The following is a description of a gene set: studied in species Mus musculus from publication Yevshin I, Sharipov R, Kolmykov S, Kondrakhin Y, Kolpakov F (PMID 30445619) Genes containing one or more binding sites for (Thap11) in their promoter regions (TSS -1000,+100 bp) as identified by GTRD version 20.06 ChIP-seq harmonization. Mouse Gene Set: THAP11_TARGET_GENES, and this is the list of marker genes: Ncln, Qrich1, Wdr45, Zfp13, Vamp1, Wdfy2, Sv2c, Kdm1a, Ccnc, Zfp398, Snord43, Vrk3, Fam53c, Zbtb8b, Acsf3, Fxr1, Zfp142, Mir1938 (NCBI Gene Id 100316693), Polr3c, Rab8b, Gtpbp2, 2310074N15Rik, Mrm3, Map3k10, Tdrd12, Zfp369, Cdc40 (NCBI Gene Id 71713), Mrpl34, Rpp30, Ksr1, Ddx49, Pex3, Polr1h, Rps27l, Bms1, Alkbh3, Zfp87, Btf3l4, Park7, Gab1, Hdac2, Adam22, Pigc, Lrrc51, Iscu, Trub1, Hcfc1r1, Cebpz, Mir6516, Marchf5, Psme3ip1, Mtmr6, Mrps10, Zscan2, 1700112D23Rik, Shpk, Klhdc3, Ints12 (integrator complex subunit 12), Slc9a1, Pigq, Rpl3, Fam222a, A530083I20Rik, Mib2, Ctdp1, Mrpl17, Slc9a8 (solute carrier family 9 (sodium/hydrogen exchanger), member 8), Glod4, Grk4, Aimp1, Zhx1, Arsk, Ubxn4 (UBX domain protein 4), Ppp1r7, Tmco1, mt-Nd6, Thoc1, Ccdc126, Sugp1, D030040B21Rik, Supv3l1, Gpt2, Suco, Snx27, Tomm20, Utp11, Cilk1, Srd5a1, Wtap, Tcf25, Fam8a1, Kif2c, Rps6kb2, 9930004E17Rik (NCBI Gene Id 654819), Cnpy3 (NCBI Gene Id 73685), Caprin2, 1700022N22Rik, Gm13610, Stx4a, Ddx18, Pemt, Gm15787, Chmp2a, H4c8 (H4 clustered histone 8), Fbxw11, Frg2f1, Pcm1, Stag3, Ighmbp2, 2500002B13Rik, Fdx2, Exo1, Zcwpw1, Cep57l1, Gstcd, Thap11 (THAP domain containing 11), Ndufb8, Slc4a2 (solute carrier family 4 (anion exchanger), member 2), Htra2, Aplf, Gpc2, Eif5b, Trmt10a, Nop14, Nfkbil1, Rnf44, Cdkn2aipnl, Cct6a, Zfp451, Psenen, Nob1, Klhl20, Xxylt1 (NCBI Gene Id 268880), Snhg16, Gid4, Napb, Ahsa1, Selenoi, Tial1, Capn15, Trappc13, Gtf2h4, Rab26os, 2610035D17Rik, Ndufaf4, Alkbh4, Gt(ROSA)26Sor, Rpl7, Kpna3, Timm22, Polr1a, 4632404H12Rik, Ube2d1, Nutf2, Trappc2b, Chmp7, Mrpl1, Foxj3, Wdfy1 (WD repeat and FYVE domain containing 1), Mir8098, Ndor1, Nosip, Gtf3c5, Vdac3, Wasf1, Pask, Klhdc4, Ube2j2, Ttc13, Smarcd1, Csrnp2, Cntd1, Calr3, Srp19, Snapc5, Mettl25b, Xpot, Lmtk3, Ift52, Cog2, Jmjd4, Agfg1, Chac2, Cox11, Otud4, Ndc1, Ablim2, Snrpd3, Ppp1r12b, Fam78a, H3f3b, Eif3c, Romo1, Zfp354c, Zcchc8, Zap70, Apba3, Calcrl, Snord14a, Iqcc, Zfp110, Srsf1, Snx3, Gm14127, Gfus, Tmem245, Haus6, Clasp1, Mtr, Ppp1r13l, Rrs1, Shmt2, Btrc, Eml6, Tbx6, Mzf1, Znfx1, Tmco3, Pfkfb2, Tssc4, Rhbdd2, Sympk, Mvb12a, Ppp1r8, Tsnaxip1 (NCBI Gene Id 72236), Calm2, Gm10863, Mxi1 (NCBI Gene Id 17859), Kctd17, Eif3g, Gm6410, Inpp5f, Ranbp10, Ufsp2, Bola3, Tmub1, Cspp1, Tecpr2, Zfp661 (NCBI Gene Id 72180), Pum3, Kbtbd7, Abce1, Akip1, Ctu1, mt-Tv, Gm25855, Drg1, Mttp, Cdc16, Atp6v1d, Ube2z, Eri3, Hpgd, mt-Tp, Spryd3, Snupn, Brix1, Zfp286, Gemin6, Aqr, Yju2, 4933404O12Rik, Rps6kc1, Hsd17b4, Atp5mc2, Kmt5b, Ppp1r14b (NCBI Gene Id 18938), Snord118, Exosc4, Gm21985, 4833439L19Rik, Gm27011, Gm15627, Rpl15, Zdhhc16, Bcl2l12, Crebl2, Nasp, Purg, Rapgef6, Zfp568, Ubl3, Tbc1d19, Rpl18a, Tardbp, Mul1 (mitochondrial ubiquitin ligase activator of NFKB 1), Thoc3, Amt, Serbp1, Tmem40, Phrf1, Atf6b, Tefm, Sf3b2, Madd, Nop2, Sar1b, Cbx1, Arl8b, Cep162, Aph1a, Cdc25a, Rpgrip1l, Mau2, Pus10, Med11, 1700008O03Rik, Spdye4b, Cdc34, Nop16, Psmd4, Tmtc3, Timm10, Clcn4, Tmem101, Rdh11, Tmem63b, Zc3h11a, Tbpl1, Maf1, Rbak, Tsc2, Cmas, Gm11205, Cdk19, Ndufs6, Mdp1, Hars1, Hspa4, Ginm1, Wrap53, Kctd5, Sart3, Wnk1, Cops4, Ap1g1, Mrps27, Brme1, Slc19a1, Zfp748, Fmc1, Zfp940, Fem1a, Dazap1, Cdca3, Psmd11 (proteasome (prosome, macropain) 26S subunit, non-ATPase, 11), Exosc1, Snw1, Cln8, Papola, Dcun1d4, Med9, Srcin1, Ift70b, Cyb5d1, Pcid2, 1500015A07Rik, Ift70a1, Wdpcp, Ftx, Mir1945, Arid4b, Gm26901, Cdk9, Psmd12, Abitram, Hbp1, Trpm8, Map2k6, Exo5, Cwc22, Hscb, Cdc42bpg, Slc4a1ap, Tfip11 (tuftelin interacting protein 11), Zfp729a, Uqcrc2, Mrpl11, Snhg20, Ift46, Zfp933, Gm15535, Fis1, Cldn12, Pde6d, Ddx19a, Zfp712, Elp6, Gmpr2, Rhbdd3, Taf9, Cenpj, 4930558K02Rik, Cyb561d2, Clhc1, Nfxl1, Calcoco1, Samd13, Hspa13, Bivm, Timm13, Rexo4, Usp35, Slc30a7, 2810414N06Rik, Kat2a, Chchd4, Asb13, Thap2, Gnl3 (NCBI Gene Id 30877), Anapc2, Lars1, Rab3c, Gspt1, Cep290, Cenpu, Kif13b, Cct4, Zfp420, Tmem208, Vti1b, Vkorc1, Cdk12, Zbtb7a, Srp68, Zfp2, Dtwd1, Smg8, Fkbp6, Zfp954, U2af1l4, Gm37292, Pigo, Trpc4ap (NCBI Gene Id 56407), Rab30, Arl14ep, Prkci, Dennd6b, Mir1955, Gm20587, Cdca5, Dhx8, Cox7a2, Dtx2, Rrp1, Actmap, Rnf6, Ubqln4, Aurka, Rplp2 (ribosomal protein lateral stalk subunit P2), Chek2 (checkpoint kinase 2), Rpl5, Dnm1, Rwdd2a, Msh4, Ubac1, Slc35b2, Zkscan3, Fyco1, Dcps, Thumpd1, Actr1a, Bod1, Nkapd1, Zc4h2, Nicn1, Fam185a, Cic, Dnajc24, Cdan1, Nsd3, Vps33a, mt-Tt, Mitf, Mir22hg, Cert1, Urb2, Dnaja3, Bola1, Nop10, Iqgap3, Safb2, Zfp354b, Morf4l1, Eif2b4 (NCBI Gene Id 13667), Zfp473, Mir5122, Nup153, Ccdc117, Gm12059, Wwox, Zbtb45, Cfap96, Agpat5, Atg4a, Gtse1, Dusp12, Sumf2, Wasl, C920006O11Rik, Atp6v1g2, Rab33b, Gm26205, R3hdm1, Coa3, 1700003G18Rik, Tsnax, Sirt2, Tcp11, Mis18a, Eef1akmt2, Ino80e (NCBI Gene Id 233875), Vps4a, Golga3, Phf23, Rbm45, Mdm4, Plagl1, 9130604C24Rik, Txlna, Nkiras2, Gm11936, Rnf115, Dmap1, Tti2, Lemd1, Tmem43, Josd2, Smim17, Insr, Nphp4, Eif3e, 9430015G10Rik, Psmg1, Macrod1, mt-Tm, Slc25a17 (solute carrier family 25 (mitochondrial carrier, peroxisomal membrane protein), member 17, NCBI Gene Id 58177), Spc25, Dph7, Nr1h3, Espl1, Cdca8, Sirt4, Psmd6 (NCBI Gene Id 66413), Zfp180, Riox2, Ralbp1, Gm26397, Cpsf1, Dnajc17, Cops8, H4c14, Unk, Prim1, Rdh10, Zfp251, Taf6, Stk31, Nfs1, Eef1akmt3, Puf60, Tfb2m, Akap8, Elmod3, Cnih4, Ccdc163, Tufm, Cipc (CLOCK interacting protein, circadian), Nek4, Syt3, Polq, Sap130, Snord3a, Lrrc47, Arpp19, Gm7008, Smndc1, Gpkow, Smg5, Spcs2, 6530401F13Rik, Hsp90b1, Helq, Eif4a1, Nup42, Gucd1, Atpaf2, Ciao3, Tmem129, Ecd, Gm13778, Fgfr1, Arv1, Armc6, Ddx31, Dnajc18, Zfp446, Wapl, Srcap, Mynn, Zfp511, Pafah1b1, Cdc26, Ndufa3, Gtf3c4, Peli1, Jtb, Mir8111, Zfp184, Ddx50, Ogfod1, Slc3a2 (solute carrier family 3 (activators of dibasic and neutral amino acid transport), member 2), Mrpl19, Ccdc57, Galm, Psmb2, Zfc3h1, Zcchc9, Pomt1, Zfp672, Cep164, Casc3, Dad1, Akirin2, Ddhd2, Rab1a, Cpox, Ro60, Pafah2, Ehmt1, Nat10, Mei4, Med17, Pde4dip, Tmem222, Phf13, Ralgapa2, Zfas1, Snrpa, Rbsn, Zfp12, Ddx39a, Rad23a, Cfap298, Hirip3, Hnrnph3, Xntrpc, Stradb, Ahcyl2, Uba1 (ubiquitin-like modifier activating enzyme 1), Mea1, Ctif, Men1, Naa38, Poglut2, Ptpn23, Kmt2d, Trim23, Zfp235, Birc6, Zfp112, Clp1 (CLP1, cleavage and polyadenylation factor I subunit), Tpr, Pgm2l1, Smarcal1, Prrg2, Xpnpep3, 4930579K19Rik, mt-Tl2, Phlpp1, Nbr1, Nsun3, Med4, Mfsd1, Cant1, Mir7672, 1810044D09Rik, Polr2j, Lig4, Vps25, Clpb, Mrpl50, Zfp263, Tha1, Myg1, Hjurp, Etfbkmt, 2810405F17Rik, Dhx38, Hspa8, Gm16069, 1110004F10Rik, Slc35b3, Pcbp2, Eif5, AV039307, E230015B07Rik, Trip4, Zfp189, Rnaseh2a, Eif4e, Nr1d1, Gm14455, Ccdc150, Def8, Supt7l, Wdr45b, Mrpl12, Cage1, Ahctf1, Tm9sf1, Vps45, Fastkd1, Kpna2, Wrap73, Ddx25, Snord42b, Hdac8, Pih1d1, Rps23, Antkmt, Faf1, Zfp770, Cul4a, Gins3, Ccar2 (NCBI Gene Id 353066), Top3a, Fsd1, Lamp1 (lysosomal-associated membrane protein 1), Ssu72, Ddost, Kbtbd8os, 1700095J07Rik, mt-Tl1, 4930453N24Rik, Dcun1d2, Banp, Vps51, Srfbp1, Gm10069, Sec11c, Scaf1, Rpl7l1, Mamstr, Phf12, Ap2m1, Pradc1, Hus1, Npl, Pank3, Snord68, Cfap61, 9130401M01Rik, Mrpl9, Mettl26, Ccp110, Pcnp, Ormdl3, Sec24a (NCBI Gene Id 77371), Exoc8, Copb2, Nxf1, Pih1d2, Tmem74, Ubald1, Gtf2i, Zfp383, Hdlbp, Psmb3, Psmc4, Rnu11, Zfp646, Dhx33, Nrde2, Zfp457, Inpp5b, Ube2n, Agbl5, Glo1, Atp5pf, Mrps33, Tex19.1, Zcchc4, Jarid2, Dpysl5, Retsat, Srrm3, 4632427E13Rik, Ptp4a1, Fbxl19, Dym, Dcakd, Tmem33, Trp53, Fbxo46, Uckl1os, Them4, Rbm17, Dmac1, Mir6359, Ddx46, Usp40, Eif5a2, Eldr, Tia1, Taf8, Cycs, Rnf121, Ubap2, Slc38a7, Ptdss2, Gen1, Zim1, Dync1li1, Trmt1l, Nedd8, Nle1 (notchless homolog 1), Gpr108, Prdm15, Zfyve1, Pbld2, Cbll1, Zfp874a, Gsk3a, Xrra1, Tmed4, Llgl1, Clcn7, Malat1, Zscan25, L3mbtl2, Mrps22, Atp13a2, Bcan, Mrpl32, H4c1, Tbck, Nme1, Gm29543, Adat1, Bcs1l, Azi2, Smim27, 8430429K09Rik, Tor2a, Prorp, Grcc10, Uqcc4, Tcof1, Zfp773, Rps19bp1, Rnf10, Phb1, Pex12, Mlec, Ppme1, Spg11, Cnot4, Lcorl, Nprl2, Snapin, Plekhj1, Wdr59, 4930579G24Rik, Chmp4b, Sdccag8, Nt5c3, Lrwd1, Zfp24, Yars2, Ift20, 4833445I07Rik, Adrm1, Nfat5, Zfp691, Slc38a9, Mtrf1, Letm1, Zfp583, Ttbk2, Toe1, Uchl5, Mrpl24, Dffb, Cherp, Mettl8, Cops5, Fkbp4, Wdr4, Upp1, Edem3, Zfp637, Rad18 (RAD18 E3 ubiquitin protein ligase), Thrap3, M6pr, Arhgef1, Usp48, Shroom3, Arel1, Tmbim4, Fbxo48, Klhl24, Zmym6, Rint1, Yes1, Rdh13, Clpp, Naa12, Zfr, Ahdc1, Pfdn5, Pfdn6, Gm25894, Katnal1, 2310022A10Rik, Dcdc5, Rpl14, Dpy19l4, Zswim9, Trim45, Cfdp1, Ap5s1, Trap1 (TNF receptor-associated protein 1), Atp5po, Mir2861, Gm22973, Ppp4r3b, Rnu7, Efcab9, Czib, Pacc1, Tmem150a, Mrpl15, Dis3, Abl1 (NCBI Gene Id 98922), Wdr70, Ptcd2, Rps9, H1f4, Rsbn1, Fam234b, Mpi, Tceanc2, Zfp93, Dnajc19, Ylpm1, Ube2h, Gatb, Vcpip1, Wdcp, Ppil2, Dgat1, Tor1aip2, Ssr2, Ap1m1, Hexim1, Ppib, Rubcn, Polr3f, B130034C11Rik, Hsbp1, Mcoln1, Zfp444, Rps26, Myorg, Stk25, Dcaf1, Sf3a2, Wdr12, Wdtc1, Commd5, Nup58, Ccdc191, Dync2li1, Mm2pr, Nsl1, Pbrm1, Sesn2, Rdh14, Chordc1, Nsfl1c, H13, Zfyve28, Fbxw8, Srsf11, Nmt1, Lamtor2, Zfp174, Mrnip, Zfp277, Rspry1, Dhodh, Vrk1, Sfxn5, Higd2a, Mettl18, Ints1, Impa2, Nudt13, Fam120c (family with sequence similarity 120, member C), Lrrc49, Thtpa, Hmgb1, Zfp692, Stmn1, Tle4, Uqcc3, Ubr4, Srrm2, Tfeb, Myl6b, Psmd10, Eif4a3, Slc12a6, Nup205, Lsm10, Ubr2, Firrm, Sipa1l3, Polk, C87436, Sprtn, Zfp668, Trmt5, Fbxo9, Zbtb40, Cog8, Smu1, Skic8, H4c3, Slc37a3, Zfhx2, Snrpd1, Carf, Rad17, Acbd5, 1110019D14Rik, Ewsr1, Pa2g4, Slc27a4 (solute carrier family 27 (fatty acid transporter), member 4), Hibch, Atxn7l2, Ints9, Nif3l1, Hp1bp3, Hnrnpm, Stxbp4, Mrps25, Mir3960, 1700042D02Rik, Rbm25, Slc33a1, Ankra2 (ankyrin repeat family A member 2), Armc8, Snord13, Aar2, Snx17, Nomo1, Tln1, S2bpcox16, Pgm3, Gpbp1l1, Tmem115, Wdr46, Etfdh, Bub3, Stoml2, Cdiptos, Zfp133-ps, Mrpl13, Man1b1, Cfap97, Smim11, Hars2, Rps3, Zfp354a, Atp6v0b, Med23, Setd1a, Fbxw9 (NCBI Gene Id 68628), Atg4c, Setmar, Klhl28, Taf2, Gm29257, Rbbp9, Ppp6c, Ric8b, 1700034P13Rik, Tmod3, Skic3, Zfp84, Neil1, Ddx23, Gm25541, Ciao1, Gpank1 (NCBI Gene Id 81845), Csnk2a1, Specc1, Gins4, Cep97, 4933417C20Rik, Ndufaf7, Dnhd1, Serpini1, Rpp21, Arl10, Man2c1, Ubxn11, Tomm22, Hace1, 4930513N10Rik, Rbck1, Smim33, Gmppa, Sh2b1, Dnajc7, Map2k5, Plekhg4, Armh3, Sugp2, Zfp606, Washc4, Drosha, Tbc1d15, Tatdn3, Ndufv1, Rptor, Rad54l2, Cbr4, C2cd3, Cryzl1, Gtpbp8, Ppp1r3c, Tlcd2, Rbl2, Rps7, Dcaf10 (DDB1 and CUL4 associated factor 10), Ncoa3, Nsun2, Ndufb7, Tmem147os, Polr1has, Rpl18, Atp5f1d, Atg101, Fam149b, Trim52, Airim, Tfpi, Rpl36, Cinp, Tbrg4, Ak6, St3gal2, Prpf31, Cdk5rap1, Sec24c (SEC24 homolog C, COPII coat complex component), Sharpin, Zfp60, Ppp1r12c, Mrpl44, Paqr6 (progestin and adipoQ receptor family member VI), Abraxas2, Emsy, Ift88, Ldah, Rab29, Mir7075, Slc35b4, Snhg17, Adprm, Commd9, Pop7, Brca1, Ubxn8, Lman2, Parp6, Ercc1, Saysd1 (SAYSVFN motif domain containing 1), Gpatch8, mt-Ts2, Zfp114, Dstyk, Zfpl1, Skp2, Atp11c, Pdcd10, Plaa, Septin2, B4gat1, Timm21, Grk5, Tacc3 (NCBI Gene Id 97263), Blm, Dimt1, Praf2, Smarcc1, Pierce2, Tmed5, Xndc1, Arhgap44, Arhgap19, Zfp219, Gm11335, Fam168a, Fam229b, Hexim2, Snap47, Cnot10, Bckdk, Ice1, Tfpt, Agtpbp1, Mir7666, Castor2, Zfp790, Duxf1, Zfp418, Rps27a, Gm5447, Afg1l, Qtrt2, Snord15a, Gm25878, Rpain, Dzank1, Dffa, Thoc6, Dus1l, Rfesd, Uspl1 (ubiquitin specific peptidase like 1), Kctd21, Zfp551, mt-Te, Dbnl, Rnf185 (ring finger protein 185), Ssrp1, Ndufaf3, Mrpl42, Wdr36, Wrn, Gm13783, Pdia5, Zfp46, Ccdc157 (coiled-coil domain containing 157), Mfn2, Trp53rkb, Gm16630, Swt1, Gm25939, Smim13, Knl1, Cops7a, Zfp334, Mrps18c, Dnajc12, Med27, Cog6, Adss2, Zkscan5, mt-Ti, Bltp2 (NCBI Gene Id 72503), Ipo7, Rida, Abcf2, Slc25a4, Rrp8, Traf3ip1, Sub1, Invs, Sys1, Tug1, Cldnd1, Snord60, C230035I16Rik, Hspd1, Epc1, Max, Lonp1, Chfr, B3galt4, Cc2d1a, Ankrd46, Ddb1, Acad8, Setd5, Tmem59, Ado, Tnfaip1, Pprc1, Crtc2, Grpel2, Sap30, Fcsk, Nabp1, Rangap1, Lta4h, Adck1, Ttc4, 9430065F17Rik, Cep104, Zfp62, B3galnt2, Ccdc107, Lmnb2, Tuba3b, Ppcdc, Rpl37, Ciao2a, Kmt2b, Acadvl, Hemk1 (HemK methyltransferase family member 1), Rnmt (RNA (guanine-7-) methyltransferase), Zfp28 (zinc finger protein 28), Cdk8, Gm16208, Sdha, Metap2, Phactr4, Lmbrd2, Zfp566, Cct3, Zcwpw2, Paxbp1 (PAX3 and PAX7 binding protein 1), Rpl10, Trmt10b, Mfsd11, Cog7, Zbed6, Rabac1, Saal1, Zfp607b, Tmed9, Atp5f1e, Fen1, Sfi1, Bet1, Mapkapk5, Clec16a, N4bp2l2, Traf7, Man2c1os, Dda1, Cep170, Fyttd1, Cenpt, Mcm3ap, Ube4b, Prmt6, Foxa3, Thap1, Daam1, Zfp738, Rbm34, Pus3, Prkab2, Mcph1, Abhd4, Taco1, Ndufs7, Car11, Sgsm3, Exoc2, Lrrc45, Sel1l, Taf5l, Cep128, Vps41, Zpbp, Cnot8, Ttc1, Mex3a, Gm24016, Pex26, Med9os, Alad, Mon1a, Tonsl, Irf3, Rrp36, Pcgf6, Zscan22, Ifrd2, Zfp41, Ppp2r5b, Ncbp2, Mrps28, Tomm7, Herc3, Sco1, Kansl1, Mmachc, Dync1h1, Zfp146, Slc38a6, Isg20l2, Pfn4 (profilin family, member 4), Plekha1 (pleckstrin homology domain containing, family A (phosphoinositide binding specific) member 1), Dock4, Ammecr1l, 5730455P16Rik, Wdr75, Fcf1, Mir3569, Rbm6 (RNA binding motif protein 6), Snx8, Acly, Snora16a, Smim30, Pigu, Aldh16a1, Terf2, Ccdc22, Bbs9, Bfar (bifunctional apoptosis regulator), Dido1, Vipas39, Atp5mc1, Ssr3, Ubl7, Txlng, Golga1, Ipo8, Cdc6, Zfp109, Ccnjl, Esco2, Aamp, Kcnn3, Agap1, Rtf2, Gdap1, Csnk2b, Pld3, Sh3gl1, Dpf1, Ppp2r3c, Glipr2, Zkscan1, Ipo13, Pnkd, mt-Rnr2, Psmg3, Dcp1a, Catspere2, Txndc15, Farsa, Chchd6, Cenpx, Sf3a3, Cnst, Kif5c, Zw10, Txnl4b, Ppig (peptidyl-prolyl isomerase G (cyclophilin G), NCBI Gene Id 228005), Ndrg3, Extl2, Snrpe, Fdps, Smg7, Fbxo27, Rpl6, Gtf2h3, Zscan12, Abcd4, Ccdc77, Mtg1, Zbtb20, Rabggta, Dguok, mt-Th, Mad2l1, Dync1i2, H4c16, Zfp768, Gm15564, Elp1, Hikeshi, Gm13421, Zik1, Zfp94, Rps3a1, Rad51, Hepacam2, Erh, Sec61a1, Txndc9, Polr1b, Edc4, Bub1b, Snx14, Tnfrsf9, Hdhd5, Psma2, Rps20, Zfp513, Got2, 2500004C02Rik, Slc39a13, Creld1, Tmem161a, Opa1, Aup1, Nr6a1, Srprb, Zfp169, Sgf29, Ncbp2as2, St13, mt-Nd2, Iftap, Ndufa9, Mindy1, Hspe1, Kbtbd6, Pphln1-ps1, Itsn1, Nup88, Rnaseh2c, 6820431F20Rik, Dnm1l, Abcc5, Tmem214, Alkbh8, Ercc6l2, Ptcd3, Chchd3, Snx1, Anapc10, Usp30, Scarna2, Foxo4, Babam1, Trim41, Psmc3, Cpeb3, Nkiras1, Gpd1l, Ifrd1, Kansl3, Gm5113, Zscan20, Ppil4, Ywhag, Vangl1, Ccpg1, Cmss1, Rab5c, 2210016L21Rik, Snapc3, Wrnip1, Zfp652, Dhx30, Acp2, Ing3, Tbc1d7, Tmem167b, Polrmt, Brpf1, Itga8, Fbf1, Snx16, Arfgap1, Utp15, Zcchc7, Mars1, Arid5a, Zfp260, mt-Nd1, Mepce, Tcf4, Nfkbib, 5830454E08Rik, Gm17484, Mutyh, Ggps1, Ncbp3, Lztr1, Pabpc1, Bicd2, Rpl13, Rab1b, Creb3, Eapp, Bcorl1, Hmbox1, Thg1l, Zmat5, Prpf19, Fibp, Nthl1, Zfp91, Eps15, Rab10os, Abhd13 (abhydrolase domain containing 13), Ap2b1, Mtf2, Tbc1d9, Tab1, Smpd3, Ubxn7, Faf2, Gstz1, Dnttip2, Matcap2, Cops7b, Depdc5, Asxl1, Stx16, Zfp787, Tyms, Krba1, Tspyl1, Kbtbd8, Slc39a9, Slc31a1, Kif3c, Stk10, Mocs1, Rpl23a, Tmem258, Ppil3, Rbm38, Ccdc146, Zfp652os, Txnl4a, Atl3, Brd3, Mir6236, Tor1aip1, Cct8, Xrn1, Ctns, Fam193a, Fam227b, Scrib, Slc25a19, Dtymk, Wbp2, Naa35, Slc35e2, Armc1, Nudt21, Prmt5, Tmem203, Synj2bp (synaptojanin 2 binding protein), Ttc14, Nup54, Fto, Eif2b1, Snhg12, Sphk2, Exoc4, Mettl1, Hsph1, Zfp111, Eloc, 1700030K09Rik, Ccdc90b, Prpf4, Rps17, Lsm14a, Selenos, Nip7, Rpl8, Kcnab2 (NCBI Gene Id 16498), Rpia, Sem1, Slc31a2, Trak2, Tasor2, Washc2, Zfp74, Dcaf17, Smim12, Crnkl1, Cnot1, Tube1, Ap2s1, Rps13, Clint1, Tmem102, Ube2q1, Zfp90, Rfx1, Tmem127, Cope, Suclg1, Itpr1 (inositol 1,4,5-trisphosphate receptor 1), Rab3gap2, Ddx47, Scamp3, Myo1e, Aacs, 1810014B01Rik, Tmem11, 9630013D21Rik, Cops9, 5430402O13Rik, Drg2, Uqcr10, Fbxl9 (F-box and leucine-rich repeat protein 9), Thyn1, Psph, Stau1, Rnf130, Ptov1, Cand1, Wdr87-ps, Edem2, Samd12, Zfp560, Sesn1, Gtf3c6, Lrrc59, Golga7, Txndc12, 5033403F01Rik, Dctn2, R3hcc1l, Gm20753, Rexo2, Zfp128, Smcr8, Cacybp, Prcc, Aak1, Crnde (colorectal neoplasia differentially expressed, non-protein coding), Ing1, Usp5, Nup133, Cdipt, Mrps31, Morc2a, Ttll4, Fancg, Cbarp, Zc3h18, Gm1401, Trappc3, Nup107, Ilk, Fgd6, Ssna1 (SS nuclear autoantigen 1), Eny2, Cdk5, Ntan1, Desi2 (desumoylating isopeptidase 2), 2610005L07Rik, 2810039B14Rik, Pop1, Mcm3, Scarb1, Tmem147 (transmembrane protein 147), mt-Nd5, Pex13, Tmem79, Psmd2, Gpaa1, Zfp879, Brms1l, Mrps2, Cdc7, Zranb3, Prpsap1, Eif2s2, Adipor2, Entrep3, Odr4, Wdr25, Zfyve19, Igsf9, Uckl1, Cdip1, Rnf216, Sdhaf3, Pcf11, Mrpl21, Prkn, Vezt, Zfp949, Mtbp, Ankrd13b, Gosr1, Zc3h15, Snord1c, Lig1, Sh3bgrl2, Gm16794, Ccdc127, Wars1, Gtf3c3 (NCBI Gene Id 98488), Togaram1, Rabl6, Mdn1, Trim32, Tarbp2, Rfc4, Gm5540, Pacrg, Zfp1, Ddx56, Rad1, Gin1, Srsf2, Fam210a, Ccdc18, Tubgcp2, Dpm3, A230103J11Rik, Erp44, Krr1, Safb, A830005F24Rik, Vps50, Haus1 (HAUS augmin-like complex, subunit 1)